The following is a description of a gene set: Human Gene Set: GSE22886_NAIVE_CD4_TCELL_VS_MEMORY_TCELL_UP Genes up-regulated in comparison of naive CD4 T cells versus unstimulated memory CD4 CD8 T cells. from publication Abbas AR, Baldwin D, Ma Y, Ouyang W, Gurney A, Martin F, Fong S, van Lookeren Campagne M, Godowski P, Williams PM, Chan AC, Clark HF (PMID 15789058) Immune cell-specific expression is one indication of the importance of a gene's role in the immune response. In order to identify such patterns, we set out to broadly profile gene expression in a variety of immune cells. studied in species Homo sapiens, and this is the list of marker genes: TM7SF3, NOTCH2NLA, PNOC, GABARAPL3, FXYD2, NPIPA1, EFNA3, MACF1, DMWD, SSBP3, ETV7, ST3GAL4, HAUS2, FAM110D, SOX4, CRTC1, ERCC3, C2, GFOD2, ZNF467, PDE4C, GNGT1, BEST1, IPP, TFAP4, GPR4, SAP30L-AS1, SATB1, NUMA1, S100A14, RIN1, UNC93B1, H2AC15, THBD, N4BP2L2-IT2, THAP4, CD55 (CD55 molecule (Cromer blood group)), CADM4, PGF (placental growth factor), DBT, LY86, FGA, MZF1, GUSBP3, PLK3 (NCBI Gene Id 1263), DNASE1L2, ALDH3B1, PKIG, CCDC28B, NPHS1, ABT1, ALOX12P2, CELF3, PICK1, NECTIN2, LZTS3, POMZP3, ZBTB20, SCNN1A, GRINA, INTS1 (integrator complex subunit 1), ZNF750, REC8, DCLRE1C, LARS1, PTGER1, TMEM260, PRKAR1B, NSDHL, LMF1, CRMP1, FAM83E, CTSV, AASS, PAK3, RAX, NAT9, SH2B2, ARID3B, MYBL2, COL6A1, HNF1B, LINC00342, HSPG2, SMARCB1, LINC01565, SUGCT, NOL6, LTBR, ZNF395, AP4S1, SIPA1L1, SKA1, CORT, CYP3A4, TMEM59L, HBP1, RABGAP1, FOXB1, ZBTB32, CERS6, IRAG2, GPATCH8, PLPPR2, SPINK2, SLC16A10, SORBS3, CDKN2B, LINC01711, ILF3, ANKZF1, GP1BA, PIERCE1, MYO15B, TSPYL2 (TSPY like 2), CDC42EP4, ID4, GRIK5, MAD2L1BP (MAD2L1 binding protein), SMG5, FOXA2, CLTCL1, PLAU, CRH, CCDC71, AIF1 (NCBI Gene Id 9471), MRTFA, BCL2L10, TSPAN32, MISP, CRCT1, HEBP1, PIAS4, XDH, CD22, BANP, ASCC1, SIPA1L3, ELANE, WASF1, LGALS13, PSD (pleckstrin and Sec7 domain containing), DHRS3, BTNL3, GAS7, MPO, TKT, TTN, BCL7A, MTPAP, VPS11, ATG16L1, PRSS1, GOLGA2, POU3F1, FGFBP1, PADI4, SCN1B, PKN2, PRB1, KCNMA1, SCN2B, GNG7, GUCA2A, HOXB9, SEMA4G, SNPH, BBOF1, TNNT2, CLUH, LIM2, JRK, RXRA, CD248, GSAP, AQP6, EPHB4, FAM169A, ARID5A, CEP152, CRISP2, PARP16, TRMU, HAPSTR1, DENND5A, PECAM1, OPN1SW, SAMD4B, CARD9, C3orf18, MMP8, HSPBAP1, EVX1, TMED1